Given this list of marker genes Tas1r1, Itpr3, Gnat1, Rgs21, Gnat3, Tas1r3, Calhm1 (NCBI Gene Id 546729), here is a description of the gene set: studied in species Mus musculus The series of events required to receive an umami taste stimulus, convert it to a molecular signal, and recognize and characterize the signal. Umami taste is the savory taste of meats and other foods that are rich in glutamates. This is a neurological process. Mouse Gene Set: GOBP_SENSORY_PERCEPTION_OF_UMAMI_TASTE